The following is a description of a gene set: Human Gene Set: GOBP_CELLULAR_RESPONSE_TO_ENDOGENOUS_STIMULUS Any process that results in a change in state or activity of a cell (in terms of movement, secretion, enzyme production, gene expression, etc.) as a result of a stimulus arising within the organism. studied in species Homo sapiens, and this is the list of marker genes: SSTR2, TP53, GIT1, FOLR1, HSP90AB1, FUT7, SCNN1B, FOS, MYOCD, DLX5, ZDHHC16, NCOA1, NEDD4, ZNF592, IGFBP2, RBBP7, COL6A1, GRB14, CRH, RHOQ, LCN2, PRKAA1, NR4A1, MIR145, MIR140, FOXO4, ZFP36L1, WNT2, CCR7, MIR23A, KDM5D, NR1D2, TGFB2, NDST1, BAMBI, CFLAR, MIR10A, CSK, HRAS, FAM89B, PELP1, INSIG2, HSPA1A, ATP2B4, SMAD4, LIMS1, ESRRA, NFE2L2, PRAME, HDAC1, ACVR1C, FOSB, FNTA, VEGFC, THBS1, HMGCS2, MIR125B1, CACNA2D3, FMOD, NDEL1, CDH3, RXFP1, GRB7, VPS18, JAK1, COL3A1, RNF111, MIR20A, LATS1, PHB1, MDM2, FGF18, TSC2, MEF2C, FLCN (NCBI Gene Id 201163), GDF5, PLPP1, DNAI1, TNFSF4, HIPK2, SRSF5, ITGB5, SULF2, PRKACA, FSHR, OCSTAMP, GH2, RARG, FOXO3, SELENOS, CA2, SLC34A1 (NCBI Gene Id 8561), KAT2B, COMP, RBPJ, CD2AP, ADIPOR2, EPB41L5, FGF8, VWC2L (von Willebrand factor C domain containing 2 like), EEF2, P2RY4, MIR27A, CPNE3, ASPN, SPHK1, CILP, GHRL, GPLD1, NCOA5, ABCB1, PAQR8, RAP1GAP, JCAD, PLCG1, SLC39A5, RAMP1, MIR1271, SLIT3 (NCBI Gene Id 6586), PIP4K2B, HGS, PAX8, NCOA4, WNT1, USP9Y, SIN3A, MIR107, TGFB3, GAS1, FGF1, ZNF366, TRIB3, RUNX2, AGTR2, TMEM119, MIR21, RXRA, TAF1, BAIAP2, FBP1, RAB10, CYP27B1, LGMN (NCBI Gene Id 5641), HDAC2, SYAP1 (synapse associated protein 1), MIRLET7F1, SLC30A10, CSRP3, PIK3R1, PDE2A, MIR329-1, PTH, PEG10, TGFB1, STAT6, ARID4B, NGF, VSTM2A, DCN, LTBP4, PCSK6, PPARGC1B (NCBI Gene Id 153346), KDM1A, NR1H3, HHEX, MIR339, ANKRD1, DAXX, MIR1298, SMAD5-AS1, MIR17, PRKCD, ARID4A, ITGB1, MAP2K3, HCRTR1, CHURC1, PRDM14, UBE2D3, MIR1224, SNCA, PHIP, TMEM53, FGFRL1, STAT3, PTPN1, SPI1, ID1, HNF4A, UBE2L3, GDF3, GDF7, EXT2, GNRHR2, TRH, COL1A2, DAND5, PIM1, CTSH, ABHD2, CCL5, PTP4A3, FGFR4, MIR342, FAM107A, MIR149, FSTL1 (follistatin like 1), PTF1A, IL10, NTRK3, SAFB, VEGFB, CYP11B1, ACVR1, CRKL, PITX3, AIFM1, CSTF2, ATP2B1 (NCBI Gene Id 490), FGF4, MIR103A1, CAMK2A, MSX2, FUT1, UGCG, TAB1, SOX10, NKX2-1, RAB35, HAP1, ILK, PARK7, SIRT1, PAK1, GDF6, CYP26A1, MIR9-1, TFPI, PADI2, ADTRP, TGFBR3L, RPS6KB2, DLL4, ADIPOQ, DKK1, MTSS2, DDX5, GKAP1, SPRY1, AKAP8, MSTN, PDGFRB, LRIT3, FBXW8, LEF1, PHOX2B, PLA2G1B, KANK2, NR5A2, WT1, FAM20C, KLF4, G6PC1, TMEM204, NDP, SLC22A12, EDN1, FKBP4, GPHB5, NLK, ANXA1 (NCBI Gene Id 301), THRB (thyroid hormone receptor beta), SPINT2, BAG4, KIF16B, GLP1R, FGF7, MICOS10-NBL1, AKR1C4, PRKD2, MIR376C, ROCK2, MIR30A, TNC, FFAR3, CLDN18, INPP5K, CSNK2B, RACK1, GCLC, KLF9, TRIP4, LRRC32, ZMIZ1, CD109, TMEM108, APC, SLC5A5, BMP2, SORBS1, PTGER2, TCF21, UBE2O, BMP7, GPR155, IDE, C1QTNF12, CDH5, UBE2D1, CORO1B, PXN, TRIM33, TGFBR3, HFE, PIAS2, WNT4, MZB1, MIR490, CBL, MIR296, PDCD4, LANCL2, TMF1, ISL1, PGR, NRP1, GPC1, SRC, SLC26A6, PIN1, OGT, CREBRF, CHRD, MIR503, DEFA1, CYFIP2, OTX2, SAFB2, TOP1, MBD5, MAPK14, HPGD, MIR424, MIR214, PPARG, SCGB2A1, TBX2, HTRA2, STAT5A, GTF2H1, SNRNP70, KNSTRN, DMD, PKM, FGFBP3, SLC2A10, SPART, RBFOX2, BMPR1A (NCBI Gene Id 8035), PTGER4, ZNF451, HDAC3, RIPK1, PAQR7, ZNF703, EMILIN1, ABL1, CYP26B1, ARRB2, CYP7B1, CRHR1, SOCS3, SMURF2 (SMAD specific E3 ubiquitin protein ligase 2), OPRD1, SMAD7, SSTR1, CUL7, HHIP, DDX17, SNW1, RANGAP1, AXIN2, INS, AKT2, ZFYVE9, PDK2, MIR199B, GCNT2, NOTCH1, PIP4K2A, HOXA13, BMP10, JUN, RAB8A, TET1 (tet methylcytosine dioxygenase 1), NPNT, IL17F, STXBP4, PAGR1, GSK3B, CRHBP, SRD5A1, ETNPPL, BPTF, MIR100, IRS2, UCN2, SGK1, HSPA8, TLR4, NR3C1, CLDN5, SP1, TSHR, MIR18A, BBS4, IGF1, POU4F2, WNT7A, DOK5 (docking protein 5), SST, PDE3B, FKBP1A, VPS54, ADAMTS7, MYO5A, LYN, APP, EGFR, MIR199A1, TWSG1, SSTR4, CAPN10, PENK, ZBTB7A, NRP2 (NCBI Gene Id 8828), LPXN, MIR520C, COL4A2, SOX6, EME1, LOX, BGLAP, FGFR2, AQP1, EXT1, ACVR2A, SFRP1, HGF, MIR101-1, CHRDL1, FBN1, RXFP2, VAMP2, ADCY8, EPN2, GATA3, CLDN1 (claudin 1), MAPKAPK2, ZFP36, MIR19B1, UFSP2 (UFM1 specific peptidase 2), HES1, PBLD, NR1H4, TAF7, ROCK1, IRS4, HIVEP1, LTBP2, MIR143, SLC27A4, MIR302C, CUL3, HES5, NOTCH2, CEACAM1, LTBP3, ZPR1, NTRK1, MIR4632, ADAMTS3, ZNF764, BRMS1L, AVPR2, FST, GAREM1, GHSR (NCBI Gene Id 92434), ATP1A3, SLC25A33, FGB, EFNA5, NDN (necdin, MAGE family member), DSG4, OVOL2, PRCP, GOT1, TSC22D1, AXIN1, CCKAR, ADRA2A, MAPK7, RXRG, TBX1, NR2E3, AMHR2, MIR196A1, HMGA2, TRARG1, MIR93, UFL1, SMAD3, SAP30, PMEPA1, PPP2R5B, CXCL13, FOXO1, SFRP2, CNOT1, NOG (NCBI Gene Id 9241), GREM2 (gremlin 2, DAN family BMP antagonist), SMOC2, SHCBP1, ZNF8, LHCGR, IRS1, PROX1, OFD1, SCNN1D, STAT1, PRKDC, ADCY6, OTOP1, NREP, SPRED2, IQGAP1, REN (NCBI Gene Id 5972), NPTN, CCDC62, USP26, ZNF536, MAGI2, CREB3L1, PKLR, CARM1, ITGB1BP1, KLB, BLVRB, PLCB1, ZNF423, MIR30B, GCLM, XBP1, ZEB1, EMD, HSPA1B, GPR150, TBC1D4, FUZ, POU5F1, CTSD, CRY1, RARA, COL2A1, APOA1, PALS1, FAT1 (NCBI Gene Id 2195), PIP4K2C, NCL (NCBI Gene Id 4691), SRARP, FUT8 (fucosyltransferase 8), ACVR2B, SERPINA12, BECN1, GLG1, TIGAR, AGRP, ZNF106, MN1, RB1, CSNK1E, VWA2, MIR885, ZBTB7B, NGLY1, ZFP36L2, TMEM107, ADAM9, BMAL1, GPC3, CCN2, DENND4C, ACTN2, CGA, RNF14, NODAL, SOS1, DEFA1B, GFRA1, AGTRAP, HSPB1, RAF1, MMRN1, FGF19, ADGRA2, WFIKKN2, FKBP1C, ADAMTSL2, RELA, FRS2, DNAAF4, HJV, GCGR, EZH2, HEYL, PAK2, PPP1R9B, FGF21, CAT, ATF2, SMAD6, PIK3C2A, PCSK9 (NCBI Gene Id 50983), FGFR3, TAC1, MKKS, FYN, MIR106A, AKT1, UCP1, PER1, PML, STK16, FGF23, CYP24A1, USP9X, ERO1A, SERPINF1, ERN1, TWF2, PDCD5, LRP2, CLOCK, CYFIP1, PGRMC2, NCOA3, MYOG, PRKCZ, ETV2, SNX5, RAPGEF1, DDIT4, KANK1, NKX6-1, PRKCE, MIR493, MTCL2, PDK4, LPIN1, APLN, PRKCI, MIR573, PARP1, GAB1, CD63, MIR361, GAS6, C2CD5, NUCKS1, TYK2, ROBO1, ATP1A2 (NCBI Gene Id 93186), CCL21, CGB3, CIB1, MIRLET7G (NCBI Gene Id 406890), USO1, NTRK2, PRMT2, APPL2, IGFBP1, ERRFI1, BLOC1S6, CAV3, SKOR2, ACOD1, CSF2RA, SESN3, BCL9, KMT2A, MIR181A2, CYP11B2, HYAL1, NPFFR2, ITGA8, PID1, NGFR, SMARCA4, TFAP2B, VEGFA, SOCS2, ALDH1A2, SCNN1G, PCK1, WASF1, RPS6KB1, RAB14, OSBPL8, MIR323A, DAB2IP, VEGFD, SKOR1, HDAC9, ONECUT2, GATA1, AR, SPRY2, EP300, SMAD9, SP100, INSRR, MIRLET7B, MYOD1, MYO1C, CTSB, TFAP4, KMT2D, LMO3, GPRIN3, ING2, ING1, NAMPT, CTSS, NPAS4, PROKR1, MIR27B, UCP3, SLC4A7, BCL9L, OR51E2, CASK, FOXP1, BMPR1B, NPFFR1, WFIKKN1, PLA2G2A, CYP26C1, ACTA2, TNXB, FKBP8, RARB, CCL19, GATA5, CRHR2, FSTL3, SOX11, DEFA3, CFL1, PTGFR (prostaglandin F receptor), GCK, ITGB3, RHOA, PTK2, MED1, GDF2, PTGDR2, NCOR1, INHBB, VEPH1, CRB2, MIR212, POR, ARK2C, FGF6 (fibroblast growth factor 6), CER1, PNPLA3, VASN, REST, VCAM1, FSTL4, PCK2, MARS1, DUSP1, EDNRA, ARF6, CEP57, ACSL1, ERFE, EIF4E, INTS9, LHB, KDM5B, CTSL (cathepsin L), ECHDC3, CALCOCO1, MIR372, SH2B2, OSTN, AVPR1B, SPRED3, MMRN2, FSHB, SLC2A8, CACNA1H, CALCA, ACE, TNS2 (NCBI Gene Id 23371), ACVRL1, PKD1L1 (NCBI Gene Id 168507), MIR195, RAB13, EIF4EBP2, MIR98, XCL1, TNFAIP6, LONP1, VDR, PTPRJ, ADGRG1, FBH1, RGMB, PROKR2, VTN, NTF4, TGIF1 (TGFB induced factor homeobox 1), DUSP3, SDCBP, LEPR, SOSTDC1, HSF1 (NCBI Gene Id 642255), NR4A3, SPRED1, LHX1, ZDHHC17, PDGFD, HCRTR2, AKR1C1, FBXO32, ERBB2, RBM4, FBXL15, ROBO2, MGARP, DYNC1LI2, ENG, HTRA3, ESRRB, ACVR1B, GREM1, STMN2, FEZ1, GSTP1, WNT5A, MIR29B1, VWC2, PPP3CA, SORT1, QRFPR, YES1, FBXW7-AS1, NCK1, PRKCA, NTF3, LRG1, LEFTY1, MIR16-1, SMURF1, SAP130, MECOM, EID2, XIAP (X-linked inhibitor of apoptosis), SCX (scleraxis bHLH transcription factor), PDGFRA, FURIN, KIDINS220, SUDS3, CPEB1, RGMA, PTPN11, DUSP22, PELO, BMP6, ADAM17, BCAR3, FOXD1, PDE3A, SMC1A, TSPAN32, NUS1, SSTR5, ERBB4, TGFB1I1, AKR1C2, IL4, PDCD6, MAP3K7, DNM3OS, FGFR1, SKP2, HDAC5, CAV1, FERMT1, INSIG1, CASR, ANKRD13C, NCOR2, UMODL1, MIR208A (NCBI Gene Id 406990), NEO1 (neogenin 1), GH1, RAB31, NFKB1, IL23R, UBR5, EGR1, MAS1, MT3, ARNT, RBX1, RBM14, GPR21, FGF9, PRKD1, MIR373, TADA3, DHRS3, CST11, ARPC3, STUB1, ENPP1, NUMA1, GPER1, TRIM68, MIR302B, ALAS1, PDPK1, GREB1L, RASL11B, PDGFB, SLX4, MTMR4, AP3S1, SNAI2, FLRT2, BMP5, GATA4, ITGA3, ELAPOR2, MUS81, FOXC2, SHOC2, PRKAA2, IGFBP7, KDR, BCAS3 (NCBI Gene Id 89751), CAD, INSR, NSMF, BRMS1, PHB2, PIK3R2, DTYMK, NR0B1 (NCBI Gene Id 8238), MT-ND3, CPS1, MIR15A, MIR204, KCP, PKD2, EHD1 (NCBI Gene Id 10938), CITED2, IL1B, PSG9, NR2C1, ESRRG, PTPN12, DOCK3, KAT2A, DDRGK1 (DDRGK domain containing 1), PRDM16, SLC9A1, CPEB2, POSTN, KDM3A, ACTN4, MAPK3, TOB1 (NCBI Gene Id 10140), SORL1, MAPK1, ZDHHC7, CRIM1, MEGF8 (multiple EGF like domains 8), NR2E1, DLX3, MIR26A1, NDNF, SLC2A4, BMPR2, BMP4, DSTYK, GNAS, GIPC1, MAPT, BRD8, RAC1, GRIA1, SMAD1, TGFBR1, CRY2, ZMPSTE24, HCN2, FZD1, LRP8, EGR3, AKT1S1, BDNF, HYAL2, LEPROTL1, UFM1, USP15, CALR, AGT, LEPROT (NCBI Gene Id 83080), NR3C2, PRKCB, GHRHR, ONECUT1, HIF1AN, DLL1, FLRT3, SREBF1, LDLRAD4, LBH, TP63, UCP2, SEMA6A, BMPER, RAMP3, SIK2, SH3GL2, TRIM72, MIR200C, RAPGEF2, FBN2, MEN1, FGF2, PTPRK, INHBA, FLRT1, NR1H2, RARRES2, CCL2, EPHA8, P2RY6, FGF5, URI1, CNOT2, SMAD2, MIR10B, TRIM24, GNG2, FGF14, PRMT1, EIF4A3, CBX3, ADAMTS12, PIK3CB, CCBE1, SKIL, SCGB2A2, LTBP1, FGF17, ACACA, BRCA1, DKK3, PRLR, DLX1, CTDSPL2, IGF2, RBBP4, CXCL8, FGF22, GATA6, CIDEA, DDX54, PKN1, JAK2, ATP5F1A, BCL2L11, MIR19A, CSH2, FRS3, NPC1, PRKCQ, KBTBD2, EPRS1, FSTL5, PTGDR, SPINT1, FGF16, NR5A1, PPARD, IGF1R, SPRY3, SOX5, FLT4, NONO, KLF2, MAP2K5, UBA5, AHCYL1, HTRA4, GSK3A, ASIP, SLC39A14, KL, ZFYVE27, MIR498, USP8, RWDD1, ASS1, SELENON, PIK3CA, HDAC6, CCN1, SCUBE3, NBL1, HRG, CDKN1C, SOST, ITGB8, SKI, ARID5A, RAMP2, SOCS7, SAP30L, PTPRE (NCBI Gene Id 5791), SCNN1A, MIRLET7A1, ANGPT2, NR2F2, ESR2, COL1A1, PHEX, ADIPOR1, VPS11, GPR22, PRKAR1A, RHOD, SPRY4, SOCS1, SULF1, NFKBIZ, SMAD5, CDK12, TBX20, CHRDL2, CNOT9, PIK3CD, OXTR, MIR497, GDF9, FIBP, MIR564, TMEM100, HIF1A, GRB2, NFIA, MSX1, TGFBRAP1, WNT10B, FZD4, ATP1A1, IL12A, FLT3, NOS1, IFT80, BBS2, IL17RD, CYP11A1, EEF1A1, WBP2, EEF2K, HAS2, CADM4, GLP2R, BMI1, GPR173, SHISA2, MIR210, JAK3, EHD4, ZMIZ2, FAM114A1, STK11, FLT1, CREBBP, E2F1, DAB2, RAP1A, MT1G (metallothionein 1G), SNX6, YWHAH, MIR183, AVPR1A, IBSP, THRA, CORO1A, CDKN2B, SGCB, MIR130A, PPP5C, CDC6, FOXC1, TRERF1, ASXL1, ANGPT1 (angiopoietin 1), TCF7L2 (transcription factor 7 like 2), AHSG, RAN, LPIN2, EGLN2, LEMD3, FGF12, NRXN1, FECH (ferrochelatase), PTPN2, FGF3, CHST11, LEP, CTNNB1, LPIN3, GHR, WNT10A, MIR146A, UCN3, MIR15B, HSPA5, KDM4C, CAV2, STRAP, YWHAG, PDE8A, TSKU, FGF10, CASP9, SFRP4, CYBA, MAPKAP1, FAM83G, SMYD3, MTOR, DDR2, NKX3-1, SSTR3, RXRB, PPM1A, METTL21C, PIK3R3 (phosphoinositide-3-kinase regulatory subunit 3), NR4A2, APAF1, RHOXF1, NRROS, STC1, HNRNPU, CSHL1, PAX9, NR1D1, SOX9, SERPINB9, LATS2, FERMT2, CD44, TMPRSS6, GALNT3, CRK, SLIT2, ACAP2, UBE3A, GDF10, CTBP2 (NCBI Gene Id 87435), SLC27A1, ITGB6, AGTR1, TGFBR2, CREB1, USF1, ZEB2, FOXA1, WDTC1, MCM7, CRIPTO, SINHCAF, SMPD3, SFR1, PRL, TRIM16, ITGA5, FOXH1, SNX25, ZYX, WWOX, SOS2, FGFBP1, AKR1C3, RGCC, CCNA2, CASP3 (caspase 3), MIR1-1, STRN3, ADISSP, RDX, SMARCC1, CSH1, HAS1, ESR1, FER, FGF20, RAP1GDS1, GNRHR, SHQ1, NPPA, VIL1, SHC1, GNB1, CITED1, GDF15, PGF, GRB10, HTRA1, BCAR1, TRIM71, MAP1B, APPL1, STAT5B, RNF6, IL12B, PPARA, PLK5, RBPMS2, GCG, MIR142, NCOA2